The following is a description of a gene set: studied in species Mus musculus Mouse Gene Set: GOBP_NEGATIVE_REGULATION_OF_EPIDERMIS_DEVELOPMENT Any process that stops, prevents, or reduces the frequency, rate or extent of epidermis development., and this is the list of marker genes: Hoxa7 (NCBI Gene Id 269740), Notch1, Srsf6, Ezh2, Hes5, Extl3, Tgfb2, Hes1, Gdf3, Dll1, Ovol2, Reg3g, Fgfr3, Msx2, Reg3a, Trp63